Given this list of marker genes Akr1c6, Akr1d1, Cyp7a1, Cyp8b1, Rxra, Cyp7b1, Hsd3b7, Ncoa2, Nr1h4, Akr1c21, Akr1c20, Cyp27a1, Ncoa1, here is a description of the gene set: Synthesis of bile acids and bile salts via 27-hydroxycholesterol Mouse Gene Set: REACTOME_SYNTHESIS_OF_BILE_ACIDS_AND_BILE_SALTS_VIA_27_HYDROXYCHOLESTEROL species: Mus musculus